The following is a description of a gene set: studied in species Homo sapiens High-frequency hearing impairment A type of hearing impairment affecting primarily the higher frequencies of sound (3,000 to 6,000 Hz). Human Gene Set: HP_HIGH_FREQUENCY_HEARING_IMPAIRMENT, and this is the list of marker genes: RPGR, SMPX, LMX1A, DSPP, POLRMT, AP1S2, GJB3, MYH9